Given this list of marker genes LSM10, SNRPB, SNRPF, LSM11 (LSM11, U7 small nuclear RNA associated), SNRPG, SNRPD3, SNRPE, here is a description of the gene set: species: Homo sapiens A ribonucleoprotein complex that contains the U7 snRNA and is required for the 3'-end processing of replication-dependent histone pre-mRNAs. Human Gene Set: GOCC_U7_SNRNP